Given this list of marker genes Cplx2, Erc2 (NCBI Gene Id 52497), Wasl, Ap1s3, Preb, Chmp5, Cd2ap, Ap1s2, Chmp4b, Stam, Slc17a7 (NCBI Gene Id 72961), Atp6v0a4, Doc2g, Rimbp2, Rab34, Stx16, Atp13a2, Atp6v1c1, Sec23b, Pmel, Atp6v1b2, Ap1g1, Ccdc136, Myo18a, Ap1b1, Bloc1s1, Trappc2, Rab38, Atp6v1g1, Stx8, Fam209, Rab27a, Rab5c, Sphk1, Picalm, Vamp8, Pla2g5, Plekhm2, Sec24b, Bloc1s4, Bet1, Spink2, Yipf5, Tmed9, Ap3b2, Agfg2, Stx11, Tsg101, Sec31b, Sar1a, Ankrd27, Agfg1, Syt5, Syt9, Vti1b, Rab3a, Snx10, Ccdc42, Snap29, Slc9a8, Tom1, Plekhf1, Clcn3, Snca, Pln, Snap47, Sec31a, Atp6v1f, Micall2, Chmp7, Rab5b, Fhip1b (NCBI Gene Id 76245), Yipf7, Chmp1b, Stx5a (syntaxin 5A), Stx2, Cylc1, Rilp (NCBI Gene Id 333615), Abca1, Trappc5, Washc1, Tyrp1, Synj1, Sdcbp, Vps11, Shroom2, Ap3b1, Cplx1, Snx33, Pi4k2b, Cplx3, Bloc1s2, Pheta1, Syt2, Trappc2l, Tmed10-ps, Trappc3, Lyst, Ap3m1, Dnm3, Apoe (NCBI Gene Id 11816, apolipoprotein E), Washc5, Rph3a, Uvrag, Golph3l, Stx19, Nkd2, Vps4a, Eqtn, Rab39, Chmp1a, Rubcnl, Sec13, Tmed10, Syt1, Ap3s1, Syt4, Chmp2b, Srpx, Slc9a6, S100a10, Nectin2, Rab29, Erc1, Syt7, Insig1, Hook1, Pafah1b1, Actl7a, Stx6 (NCBI Gene Id 98448), Sdc1, Gpr143, Snapin, Vps33b, Dcaf17, Als2cl (ALS2 C-terminal like), Slc35d3, Pi4k2a, Fnbp1l, Stxbp6, Arfgef2, Trim9, Tgfbrap1, Rab4b, Nbeal2, Stx7, Syt13, Mta1, Pikfyve, Trappc12, Sec16a, Snph, AU040320 (expressed sequence AU040320), Pla2g4a, Sec24a, P2rx7, Pik3c3, Atp6v0d1 (ATPase, H+ transporting, lysosomal V0 subunit D1), Tbc1d4, Klhl12, Slamf1, Sec22b, Tmem127, Stx1a, Tmem175, Atp6v0a1, Aktip, Exoc8, Zfp385a, Trim72, Prrt2 (proline-rich transmembrane protein 2), Garin1a, Spg11, Anxa2, Dysf (dysferlin), Snf8, Vps18 (VPS18 CORVET/HOPS core subunit), Plekha3, Prkn, Tmem9, Vamp2, Cplane2, Pheta2, Prkci, Sec24d, Usp8, Atp6v1a, Zeb2, Pdcl2, Trappc1, Zdhhc2, Trappc6a, Yipf4, Cln3, Laptm4b, Stxbp1, Chmp3, Als2, Sox30, Tbpl1, Syt11, Dnm2, Sec23ip, Vamp4, Znrf1, Trappc11, Rims1, Snap25, Grik5, a, Trappc10, Gnai3 (G protein subunit alpha i3), Sqstm1, Rims2, Syt3, Vps41, Rfx2, Golph3, Trappc13, Slc2a4, Stx12, Pla2g3, Gosr2, Atp6v1e1 (ATPase, H+ transporting, lysosomal V1 subunit E1), Znrf2, Snx3, Cc2d1a, Rab22a, Dnajc13, Rab14, Trappc9, Atp6ap2, Plekhj1, Ptbp1, Trarg1, Zpbp2, Rph3al, Hps5, Garin3, Cltrn, Doc2b, Zpbp, Uso1, Atp6v1d, Osbp, Cideb, Snx11 (NCBI Gene Id 77840), Vamp9, Ubr4, Vapb, Tmcc1, Srgn, Btbd8, Atp6v1h, Hook3, Coro1a, Actl9, Kif5b, Dlg4, Anxa8, Ap3s2, Vamp1, Gosr1, Bloc1s5, Rab7b, Kif13a, Stx17, Cd34, Aqp1, Washc4, Cul3, Vps4b, Atp6v1g2, Abcg1, Fbxo5, Baiap3, Stx3, Wdr72, Plekhf2 (pleckstrin homology domain containing, family F (with FYVE domain) member 2), Lamtor1, Atp6ap1, Cacna1b, Diaph3, Fsip1, Poc1b, Acrbp, Abcb6, Garin1b, Mx2, Rab7, Dtnbp1, Hid1, Snap23, Hps3, Chp1, Pip4k2a, Chmp6, Trappc6b, Atp6v0e2, Vamp3, Sar1b, Pdcd6, Rab8a, Sec24c, Rnf26rt, C2cd5, Aqp11, Arl8b, Cadps, Vav3, Hook2, Tmprss12, Pdcd6ip, Bace2, Arf1, Stx4a, Ccdc38, Gbf1, Bloc1s6, Anxa1, Hps1, Creb1, Vps13b (NCBI Gene Id 97991), Stx1b, Surf4, Samd9l, Cav2, Myo7a, Ap3d1, Fasl, Mapk15, Vapa, Vps39, Rufy1, Sec23a, Pip4k2b, Mia3, Unc13a, Coro1c, Septin8, Ap1s1, Doc2a, Eea1, Snap91, Kcne1, Bcl2, Snx19, Atp6v1b1, Cylc2, Ap3m2, Rab20 (RAB20, member RAS oncogene family), Pef1, Ap1m1, Atp6v1g3, Arfgap2, Zdhhc15, Zdhhc20, Rab32, Mfsd14a, Bloc1s3, Dnm1, Arfgap3, Chmp4c, Vps8, Rab11a, Hps4, Chn2 (NCBI Gene Id 74804), Serpine2, Rufy4, Vti1a, Atp6v0c, Ap2m1, Sdc4, Ankfy1, Tmf1, Rnf26, Chmp2a, Scap, Plekhm1, Sppl2c, Izumo3, Spaca1, Chmp1b2, Rab1a, Cplx4, Hps6, Syt8, Pfn4, Trappc4, Tbc1d20, Sort1, Rnasek, Usp50, here is a description of the gene set: A process that is carried out at the cellular level which results in the assembly, arrangement of constituent parts, or disassembly of a vesicle. species: Mus musculus Mouse Gene Set: GOBP_VESICLE_ORGANIZATION